The following is a description of a gene set: species: Mus musculus Mouse Gene Set: GOBP_POSITIVE_REGULATION_OF_CELL_KILLING Any process that activates or increases the frequency, rate or extent of cell killing., and this is the list of marker genes: H2-M9, Tyrobp, H2-Q1, Nectin2, H2-T5, H2-M3, Sh2d1a, Il21, Fcer2a, Ccr5, Klrc3, Stap1, Klrb1c, Slc22a13, B2m (beta-2 microglobulin), Sh2d1b1, Clec7a, H2-M10.2, Syk, Il18rap, Lamp1, Arg1, Pomc, H2-Q10, H2-M10.3, H2-M10.6 (NCBI Gene Id 399549), Klrc1, Stat5b, Itgam, P2rx7, Crtam, Il12a, Tap2, H2-M10.1, H2-M1, H2-T22, Lag3, Sh2d1b2, H2-T3, H2-Q7, Cd160, Raet1d, H2-M10.5, Stat5a, Ifng, Cxcl1, Ulbp1, Il12b, Ap1g1, H2-T13, Prf1, Ncr3-ps, Cd5l, 2410137M14Rik, Slamf6, Pvr, Ptprc, H2-T15, Cadm1, Il23a, Cd1d2, H2-K1, H2-M11, H2-T23, Xcl1, Ccl2, Fadd, H2-T24, Klre1, Mr1, Pnp, H60c, Stx7, H60b, Spi1, Klrc2, Azgp1, H2-M10.4, Cyrib, Rasgrp1, Klri1, H2-D1, Hspa8, F2rl1, Gimap3, H2-Ea, H2-Q2, H2-M2, Raet1e, H2-Q6, Klri2, H2-M5, Cd226, Gimap5, Cd1d1, Oga, Nos2, Vav1, Klrd1, Klrk1, H2-Q4 (NCBI Gene Id 436493)